Given this list of marker genes TMEM25, PIGA, ATP5MG, KIN, CBX6, ZNF143, IGF2, TGFBR1, WWTR1, GPR55, SRGN, SLC25A23, RABL3, C1orf141, GNA13 (G protein subunit alpha 13), CBX3, CC2D1A, TMEM199, MCCD1, ASIC3, TAOK1, FOXP3, ZNF345, DAG1, ZNF385A, NAP1L5, IMPG1, NKAPD1, MIOX, CLIP3, CTBP2, LRRC18, PTPRA, MEF2D, HOMER1, ZNF629, SSH2, PCDH15, BRI3BP, JADE3, PRAF2, PPP1R9B, ELAVL3, ZNF32, WNT4, MSS51, SRPRA, TNFRSF11B, EPHA3, UBAP2L, PKNOX2, TLN1, SPRED3, SSX2IP, ZDHHC15, COL9A1, N4BP3, PPP6C, AFDN, PCSK2, NUDT4, KIAA1549L, CAMTA1 (calmodulin binding transcription activator 1), RIMS2, LCLAT1, CDK6, NCR3LG1, HELZ, DLX3, TMEM214, PDGFRA, KRT13, MTCL2, H2BC18, LYSMD3, RAB31, GUCD1, WIZ, PATZ1, TFAP4, SHTN1, SLC6A15, here is a description of the gene set: species: Homo sapiens Human Gene Set: MIR5572 from publication Chen Y, Wang X (PMID 31504780) Genes predicted to be targets of miRBase v22 microRNA hsa-miR-5572 in miRDB v6.0 with MirTarget v4 prediction scores > 80 (high confidence targets).